The following is a description of a gene set: Malignant glioma is the most common central nervous system tumor of adults and is associated with a significant degree of morbidity and mortality. Gliomas are highly invasive and respond poorly to conventional treatments. Gliomas, like other tumor types, arise from a complex and poorly understood sequence of genetic and epigenetic alterations. Epigenetic alterations leading to gene silencing, in the form of aberrant CpG island promoter hypermethylation and histone deacetylation, have not been thoroughly investigated in brain tumors, and elucidating such changes is likely to enhance our understanding of their etiology and provide new treatment options. We used a combined approach of pharmacologic inhibition of DNA methylation and histone deacetylation, coupled with expression microarrays, to identify novel targets of epigenetic silencing in glioma cell lines. From this analysis, we identified >genes up-regulated by 5-aza-2'-deoxycytidine and trichostatin A treatment. Further characterization of 10 of these genes, including the putative metastasis suppressor CST6, the apoptosis-inducer BIK, and TSPYL5, whose function is unknown, revealed that they are frequent targets of epigenetic silencing in glioma cell lines and primary tumors and suppress glioma cell growth in culture. Furthermore, we show that other members of the TSPYL gene family are epigenetically silenced in gliomas and dissect the contribution of individual DNA methyltransferases to the aberrant promoter hypermethylation events. These studies, therefore, lay the foundation for a comprehensive understanding of the full extent of epigenetic changes in gliomas and how they may be exploited for therapeutic purposes. Genes up-regulated in glioma cell lines treated with both decitabine and TSA. species: Homo sapiens Human Gene Set: KIM_RESPONSE_TO_TSA_AND_DECITABINE_UP from publication Kim TY, Zhong S, Fields CR, Kim JH, Robertson KD (PMID 16885346), and this is the list of marker genes: FADS3, HCLS1, XAGE1B, GCHFR, PLIN2, PPL (NCBI Gene Id 5493), NEFL, SLC6A8, KCNV2, NXT2, NDUFA2, ATF3, CABYR, IL24, KRT7, AOPEP, TRIM58, CDA, HSD17B1, TFDP3, TPD52L1, HNF4G, HTATIP2, CDO1, MYO5C, CXADR, FGD6, SLC25A31, FAM169A, ISG20, CYP3A5, SST, IFI27, LXN, S100P, RNASET2, IL1RAP, H2BC4, IFI30, CNN1, MAGEA9, CD70, CST6, MAGEB2 (MAGE family member B2), DAZL, SAT1, IGKC, SSX1, NMB, SLC27A2, AQP3, TTC39A, RND2, STAG3, FAAH, CYP24A1, TSPYL5, CLDN7, FUCA1, PDE2A (phosphodiesterase 2A), PECAM1 (NCBI Gene Id 5175), CSPG5, COLEC11, LAMC2, TSGA10, KRT19, SAP25, PAGE1, FAM50B, CLU, MAP1LC3B, TSPAN1, SSX3 (NCBI Gene Id 10214), HSD17B6, IL1R2, LAMB3, HSPA2, TNXA, FAM242F, NR1I2, MAP7, IL18, PARD6A, KRT17, KRT23, CLIC3, H2AB3, BIK, MAGEB1, SERPINI1, SSX4, JPT1, NINJ2, DNAJB9, TOB1, TAC1, S100A3, MUC1, SERPINF1, LGMN, SSX2, MUC13, TACSTD2, FBXO2, ISYNA1 (inositol-3-phosphate synthase 1), ARL14, DBNDD2, ICAM2, H3C4, RPP25, S100A2, IZUMO4, DNALI1 (dynein axonemal light intermediate chain 1), F2RL1, FKBP1B, KRT86, TES, CDCP1, SMPD3, CDKN1A, NEFM, VAMP8 (vesicle associated membrane protein 8), RHOF, GDF15, H2AC18, IRF7, SFN, PLAAT3, TM7SF2, CCN5, TGM2, COL3A1, MAGEA4, ADIRF, HYAL1, H2BC5